The following is a description of a gene set: A plasma membrane that is part of a sperm cell. Mouse Gene Set: GOCC_SPERM_PLASMA_MEMBRANE species: Mus musculus, and this is the list of marker genes: Pkdrej, Adam6a, Adam39, Gpx5, Abhd2, Adam24, Hsp90ab1, Adam1b, Adam34, Adam20, Opn4, Adam4, Gm4787, Adam25, Adam1a, Adam30, Hsp90aa1, Adam29, Ccr6, Adam21, Tmem95, Adam34l, Adam26b, Hsp90b1, Rho, Adam6b, Hspd1, Adam26a, Lyzl6